Given this list of marker genes JAK2 (Janus kinase 2), GPR35 (NCBI Gene Id 2859), CXCR3, SLIT3, DOCK8, CCL23, CXCR6, ENTREP1, CCL18, CCR8, MIR20A, CIB1, CCL4L2, CCL19 (NCBI Gene Id 6363), CX3CL1, CCR6, CCR4, CCL22, ZC3H12A, CCR10, TFF2, CXCR2, LRCH1, CCL14, CCL16, WBP1L, CCL7 (NCBI Gene Id 6354), HIF1A, SH2B3, CCR3, CCL2, DUSP1, RBM15, CCL8, ACKR2, STK39, CCR9, CXCL10, CMKLR1, CCL5, CCL24, TREM2, CX3CR1, CXCL12, ACKR4, PADI2, CXCR4, CCR7, LOX, GPR17 (G protein-coupled receptor 17), SLIT2, RIPOR2, FOXC1, XCL2, PTK2B, MIR101-1, CCL26, CXCL13, CXCL9, CCL3, XCL1, CCL13, CCL25, GPR75, RNF113A, RIPOR1, MPL, CCL15, OXSR1, RHOA, CCL11, CCR5, THPO, SLC12A2, CCR1, CXCR1 (NCBI Gene Id 3577), LYN, CXCR5, CXCL6, CCR2, WNK1, CCRL2, XCR1 (NCBI Gene Id 2829), CCL4, ROBO1, CCL21, EDN1, ACKR1, STAT5A, CXCL11, ACKR3, CCL3L3, CCL1, here is a description of the gene set: studied in species Homo sapiens Human Gene Set: GOBP_RESPONSE_TO_CHEMOKINE Any process that results in a change in state or activity of a cell or an organism (in terms of movement, secretion, enzyme production, gene expression, etc.) as a result of a chemokine stimulus.